Given this list of marker genes Tfap2a, Tfap2d, Sumo1, Tfap2e, here is a description of the gene set: This event has been computationally inferred from an event that has been demonstrated in another species.<p>The inference is based on the homology mapping from PANTHER. Briefly, reactions for which all involved PhysicalEntities (in input, output and catalyst) have a mapped orthologue/paralogue (for complexes at least 75% of components must have a mapping) are inferred to the other species. electronically inferred by orthology from the curated human pathway studied in species Mus musculus part of: Transcriptional regulation by the AP-2 (TFAP2) family of transcription factors Reactome Pathway: Negative regulation of activity of TFAP2 (AP-2) family transcription factors